Given this list of marker genes Gm13135, Gm13123, Gm13144, Plekhm2, Gm13036, Gm13228, AAdacl4fm3, Kazn, Gm13108, Gm13158, Eef2-ps2, Pramel29, Gm13038, Aadacl3, Tmem51, Gm13148, Vmn2r-ps15, Pramel20, Oog2 (oogenesin 2), Gm13142, Ctrcos, Pramel12, Gm13169, Gm13120, Dnajc16 (DnaJ heat shock protein family (Hsp40) member C16), Oog3, Zfp991, Lrrc38, Gm13246, Vmn2r-ps16, Gm13040, Rex2, Gm13243, Agmat, Efhd2, Zfp268, Zfp933, Zfp992, Gm13058, Gm13226, Vmn2r-ps20, Gm13160, Pramel25, Zfp534, Vmn2r-ps17, Gm13024, Pramel13, Ddi2, Gm13223, Gm13170, Gm13149 (predicted gene 13149), Smarca5-ps, Gm13165, Pramel5, Vmn2r-ps18, 1700095A21Rik, Gm8178, Gm20760, Fhad1, Gm13237, Pramel27, Aadacl4fm4, Gm13035 (predicted gene 13035), Gm13136, Zfp985, Zfp986, Znf41-ps, Gm13137, Casp9, Pramel11, Gm13163, Zfp988, Gm13240, Gm13126, Gm13106, Gm13140, Gm13249, Cela2a (chymotrypsin-like elastase family, member 2A), Gm13141, Oog4, Dhrs3, Aadacl4fm5, Pramel15 (PRAME like 15), Ctrc (NCBI Gene Id 76701), Anp32b-ps1, Tnfrsf8, Gm13080, Gm13232, Gm13034, Pramel1, Pramel26, Zfp978, Gm25938, Gm21411, 4933438K21Rik, Zfp984, Fhad1os1, Gm13167, Zfp987 (NCBI Gene Id 626316), Zfp990, Gm13039, Gm13043, Pramel16, Gm13057, Gm13239, Zfp982 (zinc finger protein 982), Gm13041, Zfp989, Tmem51os1, Zfp993, Pramel13os, 6330411D24Rik, Gm13238, Gm13234, Gm13130, Gm13082, Zfp600, Pdpn, Gm21978, Gm13166, Gm13231, Rps19-ps3, Tnfrsf1b, Gm13155, Zfp980, Gm13118, Gm22039, Gm13153, Pramel4 (PRAME like 4), Gm13042, Pramel21, Pramel24, Fhad1os2, Pramel28 (PRAME like 28), 4930455G09Rik, Pramel31, Gm13161, Zfp981, Aadacl4fm1, Pramel14, Gm13104, Vmn2r-ps19, Gm13100, Gm9944, Gm13127, Pramel61, Gm13233, Zfp979, Prdm2, Gm13146, Pramel22, Platr16, Cfap107, Gm13147, Vps13d, Aadacl4, Gm13244, Gm13229, Pramel30, Mir7021, Gm13162, Aadacl4fm2, Pramel23, Gm13241, Prdx2-ps2, Gm13121, here is a description of the gene set: studied in species Mus musculus Mouse Gene Set: chr4E1